The following is a description of a gene set: Genes down-regulated in comparison of peripheral blood mononuclear cells (PBMC) from healthy donors versus PBMC from patients with acute influenza infection. studied in species Homo sapiens Human Gene Set: GSE6269_HEALTHY_VS_FLU_INF_PBMC_DN Each infectious agent represents a unique combination of pathogen-associated molecular patterns that interact with specific pattern-recognition receptors expressed on immune cells. Therefore, we surmised that the blood immune cells of individuals with different infections might bear discriminative transcriptional signatures. Gene expression profiles were obtained for 131 peripheral blood samples from pediatric patients with acute infections caused by influenza A virus, Gram-negative (Escherichia coli) or Gram-positive (Staphylococcus aureus and Streptococcus pneumoniae) bacteria. Thirty-five genes were identified that best discriminate patients with influenza A virus infection from patients with either E coli or S pneumoniae infection. These genes classified with 95% accuracy (35 of 37 samples) an independent set of patients with either influenza A, E coli, or S pneumoniae infection. A different signature discriminated patients with E coli versus S aureus infections with 85% accuracy (34 of 40). Furthermore, distinctive gene expression patterns were observed in patients presenting with respiratory infections of different etiologies. Thus, microarray analyses of patient peripheral blood leukocytes might assist in the differential diagnosis of infectious diseases. from publication Ramilo O, Allman W, Chung W, Mejias A, Ardura M, Glaser C, Wittkowski KM, Piqueras B, Banchereau J, Palucka AK, Chaussabel D (PMID 17105821), and this is the list of marker genes: RENBP, PHACTR2, LARP1, ATN1, EIF2AK2, CNN3, FCGR1A, PHC2, KDELR1, SIGLEC1, PPDPF, LMCD1, PKM, DESI1, ARHGEF11, ATP2A2, MTHFD2, LSP1, ADM, MSN, MAGEA8, ZDHHC24, DCAF15, MARCKS, SIGLEC15, IFI27, ALDOA, HPSE, LY6E, GRINA, ACACA, SPATS2L, SMG1P5, TRIM25, R3HDM4, AVL9, ACTB, PLD3, CHMP5, MS4A4A, RFX3, HLA-A, PLSCR1, TLN1, SERPINC1, FXYD6, ISG15, GRN, GNRHR, NMI, OAS2, C2, TGFB1 (NCBI Gene Id 7040), NAPA, OASL, TBC1D10B, MINK1, SIRPAP1 (signal regulatory protein alpha pseudogene 1), APOBEC3A, WAS, ABCC6, DEDD, N4BP1, NUCB1, SLC43A3, IFI6, GPSM3, SZRD1, YWHAE, LGALS9, GRB2, FKBP8, SH3BGRL3, IFITM2, ABCD1, NPL, SCAMP4, FTL, SERPING1 (NCBI Gene Id 710), MICU1, HERC5, HERC6, S100A11, SSBP3, IFITM1, S100A11P1, TLR2 (NCBI Gene Id 7097), LMNB1, IFI44, MX1, CALU (calumenin), SBNO2, RNF19B, MID1IP1, IFI44L, CD74, STRN4, LGALS3BP, IFIT1, ARF3 (ADP ribosylation factor 3), CTIF, CDK16, FKBP1A, NEK3, G6PC3, SREBF2, RAB11B, PAK2, SPI1, OAS1, MIR3648-1, PTGIR, OS9, PSME3, RAB5IF, HPS1, IFITM3P7, TFE3, ETV5, RGL1, STXBP2, GNAI2, IFITM3, STAB1, RSAD2, AGPAT1, HLA-G, EPHB2, USP18, IFI16, NFIC, ATP6V0A1, XAF1, RNF40, SLC38A6, MX2, RNASE2, ADCY2, TM9SF4, ARHGDIA (NCBI Gene Id 396, Rho GDP dissociation inhibitor alpha), CALM3, PML, IFIT3, ARNT, WBP2, CALR, CCDC86, GNAS, IGSF6, ZYX, EMP3, CTSD, TAGLN2, OAS3, AGPAT3, MACROH2A1, PAQR4, TPP1, IFI35, H1-0, KDM5C, FLVCR2